Given this list of marker genes FGFBP2, LDHC, EMILIN2, TPI1, DYRK3, STK40, RAB32, SLC2A3, ITGA5, PKM (pyruvate kinase M1/2), SLN, here is a description of the gene set: Human Gene Set: YAMANAKA_GLIOBLASTOMA_SURVIVAL_UP Better understanding of the underlying biology of malignant gliomas is critical for the development of early detection strategies and new therapeutics. This study aimed to define genes associated with survival. We investigated whether genes coupled with a class prediction model could be used to define subgroups of high-grade gliomas in a more objective manner than standard pathology. RNAs from 29 malignant gliomas were analysed using Agilent microarrays. We identified genes whose expression was most strongly and consistently related to patient survival based on univariate proportional hazards models. In six out of genes, changes in gene expression were validated by quantitative real-time PCR. After adjusting for clinical covariates based on a multivariate analysis, we finally obtained a statistical significance level for DDR1 (discoidin domain receptor family, member 1), DYRK3 (dual-specificity tyrosine-(Y)-phosphorylation-regulated kinase 3) and KSP37 (Ksp37 protein). In independent samples, it was confirmed that DDR1 protein expression was also correlated to the prognosis of glioma patients detected by immunohistochemical staining. Furthermore, we analysed the efficacy of the short interfering RNA (siRNA)-mediated inhibition of DDR1 mRNA synthesis in glioma cell lines. Cell proliferation and invasion were significantly suppressed by siRNA against DDR1. Thus, DDR1 can be a novel molecular target of therapy as well as an important predictive marker for survival in patients with glioma. Our method was effective at classifying high-grade gliomas objectively, and provided a more accurate predictor of prognosis than histological grading. from publication Yamanaka R, Arao T, Yajima N, Tsuchiya N, Homma J, Tanaka R, Sano M, Oide A, Sekijima M, Nishio K (PMID 16652150) Genes whose expression most strongly and consistently associated with the long term survival of patients with high grade glioma tumors. studied in species Homo sapiens